Given this list of marker genes SMAD3, SNW1, AMH, SMAD4, GDF11, PSG9, NOTCH1, CDKN2B (NCBI Gene Id 1030), SLC2A10, GDF7, CDH5, TWSG1, ZNF423, BMP6, ACVRL1, ENG, GPC3, RBPJ, GLCE, NGLY1, BMP2, FKBP8, ACVR2B, MSX2, HES5, TTK, SULF1, SDCBP, SMAD5-AS1, GATA4, MIR21, NUP93, FBXL15, AXIN1, ACVR1B (NCBI Gene Id 93351), ZEB2, GOT1, GIPC1, NPNT, ING2 (inhibitor of growth family member 2), EP300 (E1A binding protein p300), GDF6, SMAD2, TBX20, HIPK2, CDKN1C, SOX11, GDF5, TGFBR2, KCP, FGF9, NODAL, ARK2C, MEN1, STK11, TSC22D1, TGFB1, CSNK2B, KIAA0319, CCN1, HES1, MIR140, MYOCD, GDF2, TGFB2, NUMA1, FERMT1, HFE, BMPR2, DAB2, BMP5, CRB2, TGFB3, PARP1, CITED2, BMPER, RNF111, THBS1, PELO, TGFB1I1, BMP4, ELAPOR2, KDR, ZC3H3, MIR20A, INHBA, ACVR1, ITGA8, ADISSP, BMPR1A, BMP7, NEO1, HSP90AB1, TGFBR1, ILK (NCBI Gene Id 55522), SCUBE3, UBE2O, JAK2, CREBBP, ACVR2A, BMP10, LRG1, FLCN, FOXD1, NOTCH2, ATOH8, CITED1, SH2B1, TGFBR3, MSX1, MIR30B (microRNA 30b), here is a description of the gene set: Any process that increases the rate, frequency, or extent of the series of molecular signals generated as a consequence of a transmembrane receptor serine/threonine kinase binding to its physiological ligand. Human Gene Set: GOBP_POSITIVE_REGULATION_OF_TRANSMEMBRANE_RECEPTOR_PROTEIN_SERINE_THREONINE_KINASE_SIGNALING_PATHWAY studied in species Homo sapiens